Given this list of marker genes MMP17, EPHB2, RAC1, MTA1, LAMB1, THBS1, MMP1, TNC, THBS2, COL16A1, PAK2, here is a description of the gene set: Despite major advances in the understanding of the intimate mechanisms of transforming growth factor-beta (TGF-beta) signaling through the Smad pathway, little progress has been made in the identification of direct target genes. In this report, using cDNA microarrays, we have focussed our attention on the characterization of extracellular matrix-related genes rapidly induced by TGF-beta in human dermal fibroblasts and attempted to identify the ones whose up-regulation by TGF-beta is Smad-mediated. For a gene to qualify as a direct Smad target, we postulated that it had to meet the following criteria: (1) rapid (30 min) and significant (at least 2-fold) elevation of steady-state mRNA levels upon TGF-beta stimulation, (2) activation of the promoter by both exogenous TGF-beta and co-transfected Smad3 expression vector, (3) up-regulation of promoter activity by TGF-beta blocked by both dominant-negative Smad3 and inhibitory Smad7 expression vectors, and (4) promoter transactivation by TGF-beta not possible in Smad3(-/-) mouse embryo fibroblasts. Using this stringent approach, we have identified COL1A2, COL3A1, COL6A1, COL6A3, and tissue inhibitor of metalloproteases-1 as definite TGF-beta/Smad3 targets. Extrapolation of this approach to other extracellular matrix-related gene promoters also identified COL1A1 and COL5A2, but not COL6A2, as novel Smad targets. Together, these results represent a significant step toward the identification of novel, early-induced Smad-dependent TGF-beta target genes in fibroblasts. studied in species Homo sapiens Human Gene Set: VERRECCHIA_RESPONSE_TO_TGFB1_C4 from publication Verrecchia F, Chu ML, Mauviel A (PMID 11279127) Cluster 4: ECM related genes up-regulated in dermal fibroblasts later than 30 min after TGFB1 addition; kept increasing with time.